Given this list of marker genes RAC2, TSPO2, ID2, DIAPH3, MED1 (NCBI Gene Id 9327, mediator complex subunit 1), RB1, NEMP1, TRIM58, SP3, RAC1, DNASE2, MB, HDAC6, MAEA, CEBPG, here is a description of the gene set: The process in which a myeloid precursor cell acquires specialized features of an erythrocyte without a nucleus. An example of this process is found in Mus musculus. Human Gene Set: GOBP_ENUCLEATE_ERYTHROCYTE_DIFFERENTIATION species: Homo sapiens